The following is a description of a gene set: The chemical reactions and pathways involving inosine, hypoxanthine riboside, a nucleoside found free but not in combination in nucleic acids except in the anticodons of some tRNAs. Mouse Gene Set: GOBP_INOSINE_METABOLIC_PROCESS species: Mus musculus, and this is the list of marker genes: Pnp2, Urad, Ada, Adal, Pnp, Ak1, Uox, Urah, Xdh